Given this list of marker genes Cd28, Cox7a2l, Fos, Mef2c, Smc6, Syk, Atp5mc2, Ccr5, Ccr2, Pabpc1, Rack1, Bmyc, Tsc22d3, Nsa2, Gpi1, Klrd1, Pycard, Atf7ip, Clec12a, Foxp1, Cd209d, Fcrla, Ypel3, Zfp36l2, Smim14, Prcp, BC035044, Rnf130, Cdk4, Xist, Eef1a1, Eid1, Cdip1, Erp29, Sptssa, Snx29, Pdcd4, Marchf1 (membrane associated ring-CH-type finger 1), Atp1b1, Eef1g, Ptpn18, Ets1, Arhgef6, Lamtor4, Ppp1r14b, Tmem147, Fyn, Tep1, Eif4a2, Cd209a, Bri3bp, Nop53, Lamtor2, Ramp1, Hnrnpa1, Fau, Zeb2, Jun, Smc3, Lat2, Fth1, Marcks, Naca, Eif3e, Eef2, Trappc5, Bcas2, Dap, Eif3f, Spns3, Gm2a, Kctd12, Mxd4, Klf2, Atosa, H2az2, Slc43a2, Tnrc6b, Zfp36, Cmah, here is a description of the gene set: from publication Cui A, Huang T, Li S, Ma A, Pérez JL, Sander C, Keskin DB, Wu CJ, Fraenkel E, Hacohen N (PMID 38057668) Genes negatively differentially expressed in cell type: pDC (plasmacytoid dendritic cell) upon treatment with cytokine: IFN-β in mouse lymph nodes in vivo. studied in species Mus musculus Mouse Gene Set: CUI_PDC_IFNB_RESPONSE_DN Cytokines mediate cell-cell communication in the immune system and represent important therapeutic targets. A myriad of studies have highlighted their central role in immune function, yet we lack a global view of the cellular responses of each immune cell type to each cytokine. To address this gap, the authors created the Immune Dictionary, a compendium of single-cell transcriptomic profiles of more than 17 immune cell types in response to each of 86 cytokines (>1,400 cytokine-cell type combinations) in mouse lymph nodes in vivo. A cytokine-centric view of the dictionary revealed that most cytokines induce highly cell-type-specific responses. For example, the inflammatory cytokine interleukin-1β induces distinct gene programmes in almost every cell type. A cell-type-centric view of the dictionary identified more than 66 cytokine-driven cellular polarization states across immune cell types, including previously uncharacterized states such as an interleukin-18-induced polyfunctional natural killer cell state.